The following is a description of a gene set: Mouse Gene Set: REACTOME_PROPIONYL_COA_CATABOLISM species: Mus musculus Propionyl-CoA catabolism, and this is the list of marker genes: Pcca, Mcee, Mmut, Pccb, Mmaa